The following is a description of a gene set: studied in species Homo sapiens from publication Yevshin I, Sharipov R, Kolmykov S, Kondrakhin Y, Kolpakov F (PMID 30445619) Genes containing one or more binding sites for (ZNF776) in their promoter regions (TSS -1000,+100 bp) as identified by GTRD version 20.06 ChIP-seq harmonization. Human Gene Set: ZNF776_TARGET_GENES, and this is the list of marker genes: ENSG00000272008, ENSG00000247131, RAB3IP, FBXL9P (NCBI Gene Id 26231), BHLHE41, TMEM208, UBXN1, CASC3, ZNF292